The following is a description of a gene set: Among microtubule-targeting agents, docetaxel has received recent interest owing to its good therapeutic index. Clinical trials have underlined its potential for the treatment of advanced breast cancer, although little is known about its molecular mode of action in this context. We characterized the molecular changes induced by docetaxel in two well-known human breast carcinoma cell lines. Two mechanisms of action according to drug concentration were suggested by a biphasic sensitivity curve, and were further validated by cell morphology, cell cycle and cell death changes. Two to four nanomolar docetaxel induced aberrant mitosis followed by late necrosis, and 100 nM docetaxel induced mitotic arrest followed by apoptosis. Passing through mitosis phase was a requirement for hypodiploidy to occur, as shown by functional studies in synchronized cells and by combining docetaxel with the proteasome inhibitor MG132. Transcriptional profiling showed differences according to cell line and docetaxel concentration, with cell cycle, cell death and structural genes commonly regulated in both cell lines. Although p53 targets were mainly induced with low concentration of drug in MCF7 cells, its relevance in the dual mechanism of docetaxel cytotoxicity was ruled out by using an isogenic shp53 cell line. Many of the genes shown in this study may contribute to the dual mechanism by which docetaxel inhibits the growth of breast cancer cells at different concentrations. These findings provide a basis for rationally enhancing docetaxel therapy, considering lower concentrations, and better drug combinations. Human Gene Set: HERNANDEZ_MITOTIC_ARREST_BY_DOCETAXEL_2_UP from publication Hernández-Vargas H, Palacios J, Moreno-Bueno G (PMID 17099726) Genes up-regulated in MDA-MB-231 cells (breast cancer, mutated TP53) undergoing mitotic arrest and apoptosis after treatment with 100 nM docetaxel. studied in species Homo sapiens, and this is the list of marker genes: APOH, THBS2, LCP1, IL32, IL1RL1, MAP7, SGCB, SQSTM1, DCT, LUM, HMGA1, ITM2A, LAMA1, CD69, MCU, ASNS, SELENOP, ETV4, MARCKSL1, PHLDA1, H4C2, TYR, ELMO1, H4C3, ARPC1B (actin related protein 2/3 complex subunit 1B), MGST1, KLRK1, KLF9, PLK1, PRKD3, GADD45A, NT5E, S100A2, ARRDC4, RGP1, TYRP1, HHEX, DMWD, MT1X, MAF, C11orf68, CSF1, ABCA1, TPR, FOLR1, PLAT, LAMA4, MT2A, PRSS23, CD3D, CD68, MBOAT7, CD47, MTA3, GAGE12F, SLC1A5, TFF1, CKS2, H2AC6, SPTSSB, PLAU